Given this list of marker genes Rbm3, Rpl36, Ddx5, Klra9, Pde4b, H2-T23, Clec1a, Rpl35, Plscr2, Aldoa, Ddrgk1, Rps24, Rbm39, Cdkn1a, Tmod3, Ier3, Ablim3, Dcn, Sertad1, Meox1, Wasf2, Ppp1r15a, Smad6, Rps12, Edn1, Pkm, Sncg, Rpl12, Stat3, Rpl17, Eef1d, Socs3, Fam110d, Tax1bp1, Lima1 (LIM domain and actin binding 1), Cyb5r3, Gda, Adgrg1, Akap12, Tspan2, Slc43a3, Ankrd37, Mcam (NCBI Gene Id 84004), Rpn2, Smpdl3a, Sptbn1, Jund, Mfge8 (milk fat globule EGF and factor V/VIII domain containing), Pnrc1, Rpl4, Srrm2, Stmn2, Pxdc1, Cdh13, Ubxn2a, Irf1, Dnajc3, Gm7609, Hrct1, Cd300lg, Gas5, Clic4, Id2, H2-Ab1, Rbm25, Flt1 (FMS-like tyrosine kinase 1), Malat1, Litaf, Rsrp1, Junb, Rpl18a, Rps6, Mustn1, Itm2b, Rpl6, Ly6c1, Serinc3, Vim, Elf1, Ctla2a, Apold1, Aldh2, Anxa2, Rps25, Sh3bp5, Pfdn5, Cxcl12, Rpl10a, Abcb1a, Gbp2, Eng (NCBI Gene Id 99055), Sod1, Pecam1, Fas, Galnt18, Klf3, H2-D1, Slc6a6, Slfn2, Gpihbp1, Hey1, H2-Aa, Gstm2, Klf4, Tagln2, Tcf25, Crip1, Rpl31-ps12, Maff, Jun, Dek, Ndrg1, Bnip3, Rpl23a, Ctsd, H2-Q4, Rpl19, Cr1l, Cltb, Cd74, Fos, Id3, Ablim1, Lpl, Esam, Fmo1, Tuba1b, Gngt2, Pdlim1, Ubc, Rpl38, Timp4, Atf4, Anxa3, Cebpd, Smad7, Rps29, Lysmd2, Sqstm1, Nop53, AU021092, Rps3a1, Son, Plaat3, Csprs, Klf6, Slc3a2, Rassf1, Pcmtd1 (protein-L-isoaspartate (D-aspartate) O-methyltransferase domain containing 1), Sox18, Tubb4b, Rpl3, Tppp3, Tmem140, Tsc22d1, S100a6, Icam1, Rps19, Serpinb6a, 4930523C07Rik, Ccn1, Ehd4, Clu, Capg, Psmb8, Rpl37, B2m, Iigp1, Plat, Adam15, Xdh, Ly6a, Hspa1a, Syf2, Ercc1, Cyp4b1, Fmo2, Pim3, Psap, Kif5b, Rassf9, Rps20, Rpl21, Rbp7, Gadd45g, Ier5, Eif3e, Plcb4, Fbln2, Rpl22l1, Cldn5, Gstt1, Tinagl1, Nfib, Btg2, Epas1, Clic1, Hsp90aa1, Eef1a1, Capn2, H2bc4, Nus1, Emp2, Cd36, Mgll, Rps28, Ehd1, Meox2, Ybx1, Rpl13a, Rpl13, Calr, Rpl7, App, Camk2n1, Slc38a2, Rpl39, Tgm2, Cirbp, Rpl36a, Psmb9, Rpl37a, Rps5, Klf7, Nucks1, Sgms1, Rps23, Nostrin, Rrbp1, Anxa7, Id1, Tbx3, Plscr1, Rdx, Actg1, H2-K1, Gm15421, Pkp4, Lnx1, Snhg8, 2410006H16Rik, Use1, Pi16, Nfe2l2, Zfp36l1 (zinc finger protein 36, C3H type-like 1), Rps9, here is a description of the gene set: studied in species Mus musculus from publication Tabula Muris Consortium (PMID 32669714) Mouse Gene Set: TABULA_MURIS_SENIS_HEART_AND_AORTA_ENDOTHELIAL_CELL_OF_CORONARY_ARTERY_AGEING